The following is a description of a gene set: Heterozygous HNF1A mutations cause pancreatic-islet beta-cell dysfunction and monogenic diabetes (MODY3). Hnf1alpha is known to regulate numerous hepatic genes, yet knowledge of its function in pancreatic islets is more limited. We now show that Hnf1a deficiency in mice leads to highly tissue-specific changes in the expression of genes involved in key functions of both islets and liver. To gain insights into the mechanisms of tissue-specific Hnf1alpha regulation, we integrated expression studies of Hnf1a-deficient mice with identification of direct Hnf1alpha targets. We demonstrate that Hnf1alpha can bind in a tissue-selective manner to genes that are expressed only in liver or islets. We also show that Hnf1alpha is essential only for the transcription of a minor fraction of its direct-target genes. Even among genes that were expressed in both liver and islets, the subset of targets showing functional dependence on Hnf1alpha was highly tissue specific. This was partly explained by the compensatory occupancy by the paralog Hnf1beta at selected genes in Hnf1a-deficient liver. In keeping with these findings, the biological consequences of Hnf1a deficiency were markedly different in islets and liver. Notably, Hnf1a deficiency led to impaired large-T-antigen-induced growth and oncogenesis in beta cells yet enhanced proliferation in hepatocytes. Collectively, these findings show that Hnf1alpha governs broad, highly tissue-specific genetic programs in pancreatic islets and liver and reveal key consequences of Hnf1a deficiency relevant to the pathophysiology of monogenic diabetes. Human Gene Set: SERVITJA_LIVER_HNF1A_TARGETS_UP from publication Servitja JM, Pignatelli M, Maestro MA, Cardalda C, Boj SF, Lozano J, Blanco E, Lafuente A, McCarthy MI, Sumoy L, Guigó R, Ferrer J (PMID 19289501) Genes up-regulated in liver tissue upon knockout of HNF1A. species: Mus musculus, and this is the list of marker genes: NTF3, GADD45B, CBR1, ESCO2, CYP2A6, RRAGD, TM4SF4, LY6K, MAD2L1, RAB27A, FABP4, ADAMTS4, MTNR1A, NPNT, ENC1 (NCBI Gene Id 8507), TXNIP, CDKN1C, MMP12, LGALS1, PCDH20, PLTP, CCNB2, ATP6V0D2, IMPA2, ECT2, SLC20A1, MAOA, ADAMTS5, TMEM181, MCM2, HTRA3, ANXA2, KIF2C, ABCC4, CYP2B6, KIF20A, SLCO1A2, LEPR, CCNA2 (NCBI Gene Id 890), SLPI, RACGAP1 (NCBI Gene Id 94651), GSTT2, MMD, CBR3, TRPM4, AKAP12, NEK2, NQO1, PYGB, FGFRL1, ACOT1, KIF11, TMEM98, RGS16, GALK1, RGS2, CYP7A1, ANLN, ARHGAP18, TMEM116, PCTP, MOGAT1, ACOT4, WEE1, AFP, CYP2C19, CRAT, ABCC3, GSTM1, TMTC2, CDCA8, PTGFR, PDK4, UCP2, SLC22A5, P2RY14, SDCBP2 (syndecan binding protein 2), GSTA2, IGF2BP3, GSTM5, ABCD2, TNFRSF19, SLC7A4, MAP4K4, SCD, SERPINE1, ELOVL6, MGST3, OLIG1, SEPTIN6, FABP2, ASNS, STMN1, ACOT2, CCNB1, BUB1 (NCBI Gene Id 699), MGST2, GPRC5B, ABCB1 (ATP binding cassette subfamily B member 1, NCBI Gene Id 5243), SLC51B, RAB30 (RAB30, member RAS oncogene family), GAS2L3, GSTA1, CDC42EP5, SLC41A3, FMO3, ALDH3A2, PPARG, DBP, UBE2C, NLN, TPX2, SORBS1, SLC25A4, CDC20, LPL, THBS1, IGF2R, PER3, ME1, AKR1B10, ADRA2A, CELA3B, ADORA1, SERPINB1, CCL2, HMMR, SPARCL1, AURKB, TNFRSF12A, SULT1E1, LY6D, CYP4A22, POR, PSAT1, RAB34, FGF9